The following is a description of a gene set: Binding to a glycosylphosphatidylinositol anchor. GPI anchors serve to attach membrane proteins to the lipid bilayer of cell membranes. Human Gene Set: GOMF_GPI_ANCHOR_BINDING studied in species Homo sapiens, and this is the list of marker genes: ULBP2, PIGT, PIGU (NCBI Gene Id 128869), CEACAM5, THY1, GPAA1, FCGR3B, DPEP1, PIGK